The following is a description of a gene set: Mouse Gene Set: IKEDA_MIR30_TARGETS_UP studied in species Mus musculus Genes up-regulated in hypertrophic hearts (due to expression of constitutively active form of PPP3CA) and predicted to be targets of miR-30 microRNA. Calcium signaling is a central regulator of cardiomyocyte growth and function. Calmodulin is a critical mediator of calcium signals. Because the amount of calmodulin within cardiomyocytes is limiting, the precise control of calmodulin expression is important for the regulation of calcium signaling. In this study, we show for the first time that calmodulin levels are regulated posttranscriptionally in heart failure. The cardiomyocyte-restricted microRNA miR-1 inhibited the translation of calmodulin-encoding mRNAs via highly conserved target sites within their 3' untranslated regions. In keeping with its effect on calmodulin expression, miR-1 downregulated calcium-calmodulin signaling through calcineurin to NFAT. miR-1 also negatively regulated the expression of Mef2a and Gata4, key transcription factors that mediate calcium-dependent changes in gene expression. Consistent with the downregulation of these hypertrophy-associated genes, miR-1 attenuated cardiomyocyte hypertrophy in cultured neonatal rat cardiomyocytes and in the intact adult heart. Our data indicate that miR-1 regulates cardiomyocyte growth responses by negatively regulating the calcium signaling components calmodulin, Mef2a, and Gata4. from publication Ikeda S, He A, Kong SW, Lu J, Bejar R, Bodyak N, Lee KH, Ma Q, Kang PM, Golub TR, Pu WT (PMID 19188439), and this is the list of marker genes: Raph1, Phtf2, Cpeb2, Ptpn2, Clock, Epc2, Ddah1, Cpeb4, Ube2d2a, Ptbp3, Usp15, Celf2, Becn1, Man1a2, Usp47, Bnc2, Sema3a, Pip4k2a, Calm1, Large1, Nedd4, Rasa1, Xpo1 (NCBI Gene Id 103573), Son, Gna13, Pdcd10, Cpne8, Ywhaz, Asap1, Papola, Plcb4, Rnf44, Rrad, B4galt5 (UDP-Gal:betaGlcNAc beta 1,4-galactosyltransferase, polypeptide 5), Elmo1, Atp2b1, Rap2c, P4ha1, Sec23a, Arid4a, Dpysl2, Nfat5, Ell, Peli1, Adgrl3, Irs2, Lrrc17, Wdr7, Gnao1, Irs1, Usp34, Capza1, Marcks, Taok1, Maf, Ssbp2, Lrrc8d, Sema6d, Cdk6, Tfdp1, Ppfia1, Socs6, Slc6a6, Itsn1, Cnot6, Ncam1, Dmd, Bcl2, Galnt7, Acvr1, Fndc3b, Chd9, Jun, Map4k4, Kras, Slc4a7, Sppl3, Kdm3a, Dtna, Gtf2h1, Rai14, Arid4b, Fndc3a (fibronectin type III domain containing 3A), Actn1, Arf4, Tnrc6a, Ube2v2, Snai1, Vkorc1l1, Gm6740, Gfpt2, Cast, Ppp1r12a, Nrip1, Ccpg1, Maml1 (mastermind like transcriptional coactivator 1), Ube2j1, Scaf4, Cfl2, Tbc1d15, Xpr1, Hdgfl3, Arhgef6, Wdr44, Ccnd2, Golga4, Myh10, Nfib, Bdnf, Nova1, Ier5, Pi4k2b, Csnk1g1, Hic2, Ddx46, Ap3s1